The following is a description of a gene set: Human Gene Set: GOBP_NEGATIVE_REGULATION_OF_COAGULATION Any process that stops, prevents, or reduces the frequency, rate or extent of coagulation. species: Homo sapiens, and this is the list of marker genes: ADAMTS18, PROC, CPB2, PLAUR, PDGFA, FAP, CEACAM1, ADTRP, GP1BA, FGB, SH2B3, SERPING1, TSPAN8, FGA, THBD, CD9, SERPINE1, ANXA2, NOS3, APOH, SERPINF2, PLAU, ANXA5, HS3ST5, PF4, PROS1, F12 (NCBI Gene Id 58992), FGG, C1QTNF1, PLAT, SERPINE2, KNG1, APOE, EDN1 (NCBI Gene Id 1906), MIR19B1, KRT1, HRG, F11, TMX1, UBASH3B, PRKG1, PDGFB, VTN, SERPINB2, ALOX12, KLKB1, TFPI, PDGFRA, USF1, F2 (NCBI Gene Id 14061), PROCR (NCBI Gene Id 10544), PLG, THBS1, PRKCD